The following is a description of a gene set: Human Gene Set: GOMF_CYCLIN_DEPENDENT_PROTEIN_SERINE_THREONINE_KINASE_INHIBITOR_ACTIVITY Binds to and stops, prevents or reduces the activity of a cyclin-dependent protein serine/threonine kinase. species: Homo sapiens, and this is the list of marker genes: ANKRD42, CDKN2D, INCA1, HEXIM1, CDKN2C, KAT2B, CDKN2A, CDKN1C, CASP3, CDKN2B, CDKN1A, HEXIM2 (NCBI Gene Id 124790), CDKN1B